The following is a description of a gene set: Genes up-regulated in B lymphocytes: CpG oligodeoxynucleotide 1826 versus PL2-3 (Chromatin IC). Human Gene Set: GSE6674_CPG_VS_PL2_3_STIM_BCELL_UP species: Homo sapiens We have previously shown that rheumatoid factors (RF) produced by Fas-deficient autoimmune-prone mice typically bind autologous IgG2a with remarkably low affinity. Nevertheless, B cells representative of this RF population proliferate vigorously in response IgG2a/chromatin immune complexes through a mechanism dependent on the sequential engagement of the BCR and Toll-like receptor 9 (TLR9). To more precisely address the role of both receptors in this response, we analyzed the signaling pathways activated in AM14 B cells stimulated with these complexes. We found that the BCR not only serves to direct the chromatin complex to an internal compartment where it can engage TLR9 but also transmits a suboptimal signal that in combination with the signals emanating from TLR9 leads to NF-kappa-B activation and proliferation. Importantly, engagement of both receptors leads to the upregulation of a group of gene products, not induced by the BCR or TLR9 alone, that include IL-2. These data indicate that autoreactive B cells, stimulated by a combination of BCR and TLR9 ligands, acquire functional properties that may contribute to the activation of additional cells involved in the autoimmune disease process. from publication Busconi L, Bauer JW, Tumang JR, Laws A, Perkins-Mesires K, Tabor AS, Lau C, Corley RB, Rothstein TL, Lund FE, Behrens TW, Marshak-Rothstein A (PMID 18025183), and this is the list of marker genes: SMIM30, FAM174A, MTURN, HIGD2A, USF1, TIMM22, RWDD2A, RILPL2, PRKACA, DARS2, SEPTIN8, PRDX4, IPCEF1, PDZD11, PHPT1, SUGP1, NUBPL, TM2D2, AAMDC, COMMD4, COMMD3, MED30, PTS, ETFDH, PYCARD, CEP83-DT, RIDA, PAGR1, FAM216A, TOMM6, HEXIM1, CNPY4, FAM32A, MSL3, AKR1E2, MPP1, DECR1, SETD7, EIPR1 (EARP complex and GARP complex interacting protein 1), FAM229B, CRYL1, LCMT1, FIS1, VCPIP1, CARMIL1, VRK1, WDPCP, MXD4, DHRS1, FFAR2, MRNIP, TRAF3IP3, PRCC, SKP1, DSN1, FUNDC1, WDR35, DPCD, NME7, ROM1, COQ9, TSPO, APIP, TMEM106C, TSPAN3, PSMD10, SIRT4, TMT1A, TMEM38A, TSPAN32, MPV17, CD9, H2BC13, NDUFB9, JMJD8, PEX7, MFSD11, MORN2, GINS4, GABARAPL2, SEM1, CAMLG, GOLT1B, GRN, DGCR6, SLC35F5, TCF7, CBR4, CTSV, PPP1R16A, PHF7, ARL4D, HTATIP2 (NCBI Gene Id 10553), NPHP1, RPGR, ELOF1, C19orf53, EVL, TXNDC16, YIPF1, TMBIM4, MATCAP2, PARS2, RPAIN, TRAPPC2L, SMIM8 (NCBI Gene Id 63914), PSME3IP1, ZPBP2, CEP19, HSD17B11, MTMR14, TIMP2, OTUB1, FECH, MRPL27, TRPM1, INTS9, CEP70, MRPS33, TST, ALKBH4, SPO11, ZFYVE26, CBY1, UROD, ATG101, TXNIP, RSU1, GGACT, SLC25A20, TSPAN2, B9D1, RETSAT, MCEE, PI4KB, DPP4, MS4A6A, COG4, ZC3H12D, AFF3, IFT140 (intraflagellar transport 140), DNAAF10, SCP2 (sterol carrier protein 2), HADH, ZBTB11-AS1, MPLKIP, ATP6V1G2, LRRC28, IFT22, ENSG00000286190, ZFYVE19, CD1D, SSU72, ARL16, BCO2, CYRIA, AXL, DGLUCY, RNASEH2A, GMPR2, CHEK2, CD3G, C6orf118, TMEM141, ETFA, MZT2B, PPP1R21, ADCK5, TMEM101 (NCBI Gene Id 84336), SORBS1, MXD3, SLC25A12, RFX5, GBP4, SMPD2, CYB5R4, ARL6, TMEM106B, CD27, ROPN1L, IDNK, INPP5K, CXXC5, AKR1B10, NUDT7, OARD1, TMEM242, SBK1, TNFRSF13B, TCF19, ACAA1, OIP5, TMEM216, CNP, COX7A1, NQO2, HYLS1, ACAA2, MDH1, RASGEF1A